The following is a description of a gene set: studied in species Homo sapiens from publication Lin JX, Li P, Liu D, Jin HT, He J, Ata Ur Rasheed M, Rochman Y, Wang L, Cui K, Liu C, Kelsall BL, Ahmed R, Leonard WJ (PMID 22520852) Genes up-regulated in T cells stimulated by IL2 for 17h: STAT5 double knock-in versus wildtype. Cytokine-activated STAT proteins dimerize and bind to high-affinity motifs, and N-terminal domain-mediated oligomerization of dimers allows tetramer formation and binding to low-affinity tandem motifs, but the functions of dimers versus tetramers are unknown. We generated Stat5a and Stat5b double knock-in (DKI) N-domain mutant mice that form dimers but not tetramers, identified cytokine-regulated genes whose expression required STAT5 tetramers, and defined consensus motifs for dimers versus tetramers. Whereas Stat5- deficient mice exhibited perinatal lethality, DKI mice were viable, indicating that STAT5 dimers were sufficient for survival. Nevertheless, STAT5 DKI mice had fewer CD4+CD25+ T cells, NK cells, and CD8+ T cells, with impaired cytokine-induced proliferation and homeostatic proliferation of CD8+ T cells. DKI CD8+ T cell proliferation following viral infection was diminished and DKI Treg cells did not efficiently control colitis. Thus, tetramerization of STAT5 is dispensable for survival but is critical for cytokine responses and normal immune function. Human Gene Set: GSE36888_STAT5_AB_KNOCKIN_VS_WT_TCELL_IL2_TREATED_17H_UP, and this is the list of marker genes: TOMM34, ZHX2, SLC15A3, LYSMD2, USP24, PLSCR1, MDFIC, POU6F1, ING5, LIME1, TOR1B, WFIKKN2, PPRC1, S1PR1, ITGA6, LRP5, SSBP2, GM2A, MRPS16, GTF2I, SLC1A5, IL18 (interleukin 18), GUK1, AQP3, POPDC2, RETREG1, IER3, PARP8, COX15, KIF1B, REXO2, DDX3X, TMED3, MRPS24, BDH1, PRKCZ, CDON, SMCO4 (NCBI Gene Id 56935), TRAM2, DUSP12, HSD17B11, CD68, MTF1, FAM174C, ANKRD13C, PDRG1, NRBP1, TAF4B, CYLD, HERPUD2, MRI1, DNAJC13, SEMA4F, XRCC5, MCCC1, KBTBD11, CD86, RGS11, ISG20, SLC25A32, AFF1, DGLUCY, RRM2B, CROT, ARHGAP5, DDX28, PRMT3, KIAA2013, HGSNAT, COMMD6, HVCN1, NR1D2, IFIT1B, BATF, LYRM2, SRPK1, SELENOO, CNP, MRTO4, PON2, PTEN, GTF3A, DNAJB5, PCMTD1, SYNJ1, DERL2, FHIP1B, PHC3, PPP2R5C, DHRS7, ABCC1, MAP6, ZDHHC18, TOR1AIP1, MARCHF2, SPSB3, MOB1A, ABHD6, BEND4, RRP1B, CMPK2, TBC1D8B, TIMM23, EEIG1, FCGR2B, TNFSF14, MTLN, CXCR3, UBQLN2, VKORC1, RRP15, RSBN1, POLR1A, MYC, DTD1, RASL11A, ZBTB32, SELL, SNX17, HOOK1, VAV3, EMB, HSCB, GPR12, RECK, SETD6, CRTAM, CCR7, GPR183, ENDOG, CALHM6 (calcium homeostasis modulator family member 6), USP45, PGAP6, USP48, ATP1A1, CCR2, CAST, TLR1, SERPINB1, G3BP2, PFKP, ALDH3A2 (aldehyde dehydrogenase 3 family member A2), NT5C, ASS1, SIDT1, WDR43, IKBKE, UBXN2A, URB2, XKR8, FABP1, EZH1, SYNE2, NIPSNAP1, DENND10, AEN, ERAP1, CLCC1, GSTO1, RPS19, TNFRSF25, RDH12, CD2AP, SIT1, RPL36, CHMP1B, NOC2L, SLAMF6, POLR1D, TSR1, AHCTF1, POLR3E, ADPGK, LEPROT, RAPGEF6, TTC39C, AFF3, UTP14A, ALG3 (ALG3 alpha-1,3- mannosyltransferase), ECE2, NOL8, IFIT1, RPL18A, GDPGP1, CHMP1A (NCBI Gene Id 5642), IL7R, NFATC2, CD27, DUS2, PECAM1, SAR1B, DNAJB9, SLC35A5, CBLB, BCAP29, RUNX2, PDXK, TCF7, NSG2